Given this list of marker genes ANKRD12, OTUD1 (OTU deubiquitinase 1), MDM4, TXLNA, WBP4, C1QB, ARF6, SRI, DAPK1, NECAP2, SPG11, SETX, SLCO2B1, IQCE, DCUN1D1, BLTP2, SLC25A30, PSMA3-AS1, MARCHF8, SYT8, JARID2, MPHOSPH8, MOBP (myelin associated oligodendrocyte basic protein), ABCA3, TOX, KCNK6, BTBD7, SP2, ZNF618, P2RY6, UBN1, ORAI1, CST7, SUB1, CXCL8 (NCBI Gene Id 3576), DOK2, HCFC2, SLC66A2, ARHGEF12, DCK, PDE4C, ADCY7, CAMK1D, C1QC, HDAC4, FGL2 (NCBI Gene Id 10875), IL13RA1, MBD6, ABCA7, CCDC112, GCC2, PTGER2, PAK2, IFT25, RFFL, PSEN1, IL23R, DDHD2, PKN2, STAT5B, DCBLD1, GUSBP3, SUDS3, SGPL1, CDK13, DNAJC21, SEMA4F, BLNK, PCYOX1, PHF2, ZNF555, CERS6, CMTM6, SMG5, ATF7IP, FBXW12, SLC25A48, SOCS1, NIPAL2, MAP3K13, IGF1R, PKD1P6, ZNF704, RNASE6, FPR3, KMT5B, TDRD7, CTCF, AAGAB, CASP1, RNF169 (NCBI Gene Id 254225), TBC1D5, FTX, SEC14L1, HLA-DPA1, TMEM87A, RASAL1, CD1C (NCBI Gene Id 911), AFF1, GCNT1, ZNF451, CCR6, MVB12B, LTB, GRK3, SNRNP200, ZNF789, PTPRJ, INSIG2, FN3KRP, DIP2A, ARL13B, TNFRSF14, EIF4ENIF1, ATXN7, AHCYL2, CEP350, PTBP3, CEP15, TRIM25, C12orf57, PUM2, ATP2B1, ACSL5, SSBP2, CHORDC1, VPS13B, HLX, OTUD3, SNRNP25, KDM4C, SCRN1, FAM50A, CST4, TAF4, KRCC1, MKNK2, SS18L1, APBA3 (amyloid beta precursor protein binding family A member 3), PALS1, BTAF1, HERC1, ZFP3, ABCA6, EFHD2, NFATC2, INTS15 (integrator complex subunit 15), AKAP11, JAK1, RLF, FLVCR2, AHNAK, HACD2, ZZEF1, LIX1L, PIP4K2A, ARL6IP6, CLASP1, ZCCHC14, IPCEF1, PDS5A, FZD3, ZNF354A (NCBI Gene Id 6940), NUB1, SACM1L, VAMP3 (NCBI Gene Id 9341), IL6R, FOXP1, STK38L, MYRF, KIDINS220, ANXA7, UBXN2A, NLN, ZC3H7A, BATF3, HIPK1, WDR47, RNF144B (ring finger protein 144B), STAT5A, FAM241A (family with sequence similarity 241 member A), ZCCHC8, MPPE1, DCLRE1C (DNA cross-link repair 1C), ATL3, BCL11A, FGL1, LNX2, HNRNPR, SENP7, SPG7, CALHM6, TBC1D17, RNF114, AKAP17A, here is a description of the gene set: Human blood monocytes were differentiated over six days with either 100 ng/ml M-CSF or 1 umol/l CXCL4 In atherosclerotic arteries, blood monocytes differentiate to macrophages in the presence of growth factors like macrophage colony-stimulation factor (MCSF) and chemokines like platelet factor 4 (CXCL4). To compare the gene expression signature of CXCL4-induced macrophages with MCSF-induced macrophages or macrophages polarized with IFN-γ/LPS (M1) or IL-4 (M2), we cultured primary human peripheral blood monocytes for six days. mRNA expression was measured by Affymetrix gene chips and differences were analyzed by Local Pooled Error test, Profile of Complex Functionality and Gene Set Enrichment Analysis. genes were differentially expressed between MCSF- and CXCL4-induced macrophages, 206 of them overexpressed in CXCL4 macrophages coding for genes implicated in the inflammatory/immune response, antigen processing/presentation, and lipid metabolism. CXCL4-induced macrophages overexpressed some M1 and M2 genes and the corresponding cytokines at the protein level, however, their transcriptome clustered with neither M1 nor M2 transcriptomes. They almost completely lost the ability to phagocytose zymosan beads. Genes linked to atherosclerosis were not consistently up- or downregulated. Scavenger receptors showed lower and cholesterol efflux transporters higher expression in CXCL4- than MCSF-induced macrophages, resulting in lower LDL content. We conclude that CXCL4 induces a unique macrophage transcriptome distinct from known macrophage types, defining a new macrophage differentiation that we propose to call M4. species: Homo sapiens Human Gene Set: GSE20484_MCSG_VS_CXCL4_MONOCYTE_DERIVED_MACROPHAGE_DN Genes down-regulated in monocyte derived macrophages: CSF1 versus PF4. from publication Gleissner CA, Shaked I, Little KM, Ley K (PMID 20335529)